Given this list of marker genes Tapt1, Homer3, Ednrb, Trp53bp2, Chd6, Fnip1, Hbp1, Igf2bp1, Zcchc3, Dip2a, Mapk8, Igdcc4, Lrrtm3, Cbfa2t3, Hoxc8, Eef2k, Atp8b4, Ntrk2, Zfp182, Dcdc2a, Igf2bp3, Hoxa9, Diaph2, Hoxb7, Nme4, Slc9a6, Zfp609, Osmr, Vsnl1, Dnm3, Nr2c2, Trerf1, Ecm2 (extracellular matrix protein 2, female organ and adipocyte specific), Psmd11, Gpcpd1, Cep350, Rdx, Nras, Pbx1, Kdm1b, Nr6a1, Sh3gl2, Epha7, Rtl6, 5730480H06Rik, Stox2, Cpd, Adamts12, Aqp4, Hand1, Zmynd11, Pcdh19, Tet1, Rbms2, Hoxa5, Fgfbp3, Epha4, Fasl, Usf3, Snx16 (NCBI Gene Id 99711), Klrd1, Lrig2, Plpp6, Gata6, Eri2, Eps15, Rgs17, Hoxb6 (homeobox B6), Map4k3, Pbx3, Fhdc1, Hip1, Gtf2a1, Tafa5, Kcnc2, Mecp2 (methyl CpG binding protein 2), Ccdc47, Pard6b, Lrrc75b, Fbxw2, Ing5, Cask, Prtg, here is a description of the gene set: from publication Chen Y, Wang X (PMID 31504780) Mouse Gene Set: MIR_196B_5P Genes predicted to be targets of miRBase v22 microRNA mmu_miR_196b_5p in miRDB v6.0 with MirTarget v4 prediction scores > 80 (high confidence targets). studied in species Mus musculus